The following is a description of a gene set: species: Homo sapiens Any process that activates or increases the frequency, rate or extent of unsaturated fatty acid biosynthetic process. Human Gene Set: GOBP_POSITIVE_REGULATION_OF_UNSATURATED_FATTY_ACID_BIOSYNTHETIC_PROCESS, and this is the list of marker genes: ABCD2, AVPR1A, CD74 (NCBI Gene Id 972), PLAA, PLA2G3, ABCD1, IL1B, AVP, PTGS2